The following is a description of a gene set: Human Gene Set: GOBP_MATURE_B_CELL_DIFFERENTIATION studied in species Homo sapiens The process in which transitional stage B cells acquire the specialized features of mature B cells in the spleen., and this is the list of marker genes: DOCK11, RAG2, ADAM10, BCL3, FCGR2B, CR1, SLAMF8, ST3GAL1, CDH17, ADA, DOCK10, PHF14, CD19, PLCG2, NKX2-3, PLCL2, MFNG, IL6, ITFG2, DDRGK1, ITM2A, PTK2B, IL2RG, DLL1, LGALS8, NOTCH2, CMTM7, GPR183, MALT1, POU2AF1, IL2, IL10, IRF8, LFNG, XBP1, NFKBIZ, LGALS1, TAOK3, IL21, C17orf99, SPI1, BCL6